Given this list of marker genes vif, env, gag, nef, vpr, CXCR4, vpu, gag-pol, CD4, PPIA, CCR5, rev, here is a description of the gene set: Reactome Pathway: Binding and entry of HIV virion part of: Early Phase of HIV Life Cycle HIV enters cells by fusion at the cell surface, that results in a productive infection. The envelope (Env) protein of HIV mediates entry. Env is composed of a surface subunit, gp120, and a transmembrane subunit, gp41, which assemble as heterotrimers on the virion surface.The trimeric, surface gp120 protein (SU) on the virion engages CD4 on the host cell, inducing conformational changes that promote binding to select chemokine receptors CCR5 and CXCR4.<br>The sequential interplay between SU, CD4 and chemokine coreceptors prompts a conformational change in the transmembrane gp41. This coiled coil protein, assembled as a trimer on the virion membrane, springs open to project three peptide fusion domains that 'harpoon' the lipid bilayer of the target cell. A hairpin structure (also referred to as a "coiled coil bundle") is subsequently formed when the extracellular portion of gp41 collapses, and this hairpin formation promotes the fusion of virion and target cell membranes by bringing them into close proximity. Virion and target cell membrane fusion leads to the release of HIV viral cores into the cell interior.<br> studied in species Homo sapiens